The following is a description of a gene set: A ribonucleoprotein complex that contains at least one RNA of the small nuclear RNA (snRNA) class and as well as its associated proteins. These are typically named after the snRNA(s) they contain, e.g. U1 snRNP, U4/U6 snRNP, or 7SK snRNP. Many, of these complexes become part of the spliceosome involved in splicing of nuclear mRNAs. Others are involved in regulation of transcription elongation or 3'-end processing of replication-dependent histone pre-mRNAs. species: Mus musculus Mouse Gene Set: GOCC_SMALL_NUCLEAR_RIBONUCLEOPROTEIN_COMPLEX, and this is the list of marker genes: Snrpd1, Sf3b3, Larp7, Snrnp40, Luc7l, Txnl4a, Sf3b2, Prpf40a, Lsm6, Snrpa1, Luc7l2, Arfgef1, Snrpc, Ddx39b, Txnl4b, Ppih, Prpf4, Cd2bp2, Nolc1, Snrpb2, Phf5a, Ddx23, Slu7 (SLU7 splicing factor homolog (S. cerevisiae)), Lsm7, Snrpn, Snrpb, Snrpd3, Lsm10, Rbmx2, Sf3b4, Usp39, Lsm8, Snrpa, Snrpd2, Prpf40b, Lsm5 (NCBI Gene Id 72095), Sart3, Snrpg, Prpf31, Snrnp200, Luc7l3, Sf3b5, Sf3b1, Sf3a1, Prpf39, Eftud2, Prpf3, Prpf6, Snrpf, Ppihl, Prpf8, Snrpe, Larp7-ps (La ribonucleoprotein 7, transcriptional regulator, pseudogene), Sf3a2, Sart1, Lsm11, Snrnp70, Mepce, Zmat2, Hexim1, Snu13 (SNU13 homolog, small nuclear ribonucleoprotein (U4/U6.U5)), Snrnp27, Rbm42, Snrpert, Htatsf1, Prpf18 (NCBI Gene Id 67229), Tssc4, Lsm2, Lsm4, Lsm3, Sf3a3